Given this list of marker genes Mpp7, Epha2, Fermt2, Mcam, Ncf2, Lamtor1, Slitrk3, Wasf1, Rab7, Pak4, Pik3r2 (phosphoinositide-3-kinase regulatory subunit 2), Slitrk5, Ocrl, Vangl1, Pgrmc2, Arhgap42, Ophn1, Rac3, Arhgap15 (NCBI Gene Id 76117, Rho GTPase activating protein 15), Lbr, Baiap2l1, Noxa1, Emd, Esyt1, Cyba, Arhgap26, Arhgap17, Vrk2, Prex1, Depdc1b, Ncf1, Cdc42, Noxo1, Arhgdib, Swap70, Nox3, Racgap1, Lman1, Cav1, here is a description of the gene set: electronically inferred by orthology from the curated human pathway This event has been computationally inferred from an event that has been demonstrated in another species.<p>The inference is based on the homology mapping from PANTHER. Briefly, reactions for which all involved PhysicalEntities (in input, output and catalyst) have a mapped orthologue/paralogue (for complexes at least 75% of components must have a mapping) are inferred to the other species. studied in species Mus musculus Reactome Pathway: RAC3 GTPase cycle part of: RHO GTPase cycle